The following is a description of a gene set: Human Gene Set: PULVER_FOREY_CELLCYCLE_PEAKING_G2 Transcription regulation during the cell cycle is crucial for ensuring genes are expressed at the right time and in the correct amounts, coordinating key processes like DNA replication, mitosis, and cell division. In our study, Genes whose expression fluctuates during the cell cycle (pVal < 0.05) and peaks in G2 (G2) in K562 studied in species Homo sapiens, and this is the list of marker genes: TENT4A, LYPLA2, SPAG7, KIF23, KAZN, SMARCA4, OR2W3, GTF3C2, UCP2, DNPEP, TBCD, LMAN2L, CCT3, VARS2, RBM19, SLC10A4, TRAP1, PSKH1, TMEM185B, MTHFR, MAP1B, TMEM87A, KIF20B, TMEM250, MAP2K7, RAB1B, ENPP3, RRP1, CAMTA2, JAK2, AP2B1, APEX1, CD151 (CD151 molecule (Raph blood group)), BOD1, RBSN, RFT1, PSMC3, DDX39A, ARHGAP35, YIF1A, DNAJA3, CCNG2, MSL1, NELFE, DPF2, EFTUD2, PPIL2, SMARCB1, MRPL12, POLH, PLCD1, MEX3C, FBXW5, NFIX, CLPP, ASCC2, CUX1, CAVIN2, DCPS, DCAF15, SASH1, MED16, LMLN, MRPL28 (mitochondrial ribosomal protein L28), IRF2BP2 (NCBI Gene Id 359948), ARHGAP4, RCCD1, KMT5A, LSR, NPRL3, PLCL1, CENPC, CDR2, HECTD4, MBD6, ASCC1, NDC80, CDCA2, ANLN, ARAF, WNK4, TNFRSF8, BRD4, SGSM3, SPAG5, CCDC77, CYTH2, VPS37C, CENPT, STK36 (serine/threonine kinase 36), DIS3L2, UBL4A, SNX17, MUC1, NISCH, AFG2A, TUBGCP2, COL25A1, EPN1, BAMBI, MMP17, FADD, GAB2 (NCBI Gene Id 9846), PTPN7, SETD1B, DCTN2, MLST8, CHMP7, ABCC1, VPS4A, R3HDM2, STK25, ARID1B, DTYMK, CERS2, MYO3B, BAG6, USP54, TSEN2, SNAPC3, PARPBP, ACTN1, VAC14, SLC40A1, EVL, UBXN10, GATAD2B, PGP, ID1, PSAT1, AAAS, MON1A, GATA2 (NCBI Gene Id 84724), TAF8, INTS1, ARHGAP19, NMT1, HYAL2, CIZ1, HIPK2, F2RL3, SPOUT1, CEP250, DMAP1, MECP2, DUS1L, AKT1, PNRC2, BICRA, SNRPA, DCAF4, MMAB, TTK, ZNF414, FARSA, CDC25C, PPM1E, CTDNEP1, WIZ, INPP1, COQ5, RNF214, COPS7B, WDR62, MTHFD1L, CABIN1, TXNDC15, TPX2, RAB3GAP1 (NCBI Gene Id 338380), STRIP2, PFKP, PITX1, HDDC3, RPTOR, IGF2BP2, FPR3, NQO2, NUTM2A (NUT family member 2A), VPS51, CENPI, HK1, GP6, MKI67, CMTR1, EPHB4, PLXNA1, TTC9C, LIG3, SEMA4B, C10orf95, LSM2, MTRFR, ACTN4, HCG27, PFKL, POC5, SLC6A9, USP5, AURKB, SLC35A4, ATL2, FADS2, MPDU1, IL16, ARHGAP11A, CLASP2, WDR18, PPP1R35, IGFBP4, ZNF518B, NUSAP1, EARS2, SUGP2, STC2, ZNF628, BORA, SGF29, RHEB, MED22, CCDC97 (NCBI Gene Id 90324, coiled-coil domain containing 97), SAMD4B, NOC4L, SCAMP4, TARS2, KNL1, SPEN, NUDT6, STARD8, MADD, SAP30, ZNRF3, ARHGDIA (Rho GDP dissociation inhibitor alpha), CMSS1, BICD1, BEX1, DSTYK, HARS1, ABCF1, FAM193A, SEC22C, TAF5, PCK2, ZC2HC1C, SLC7A5, NEU3, MICAL3, ATF4, ZNF574, C3AR1, LMNB1 (NCBI Gene Id 445266), SLC27A2, CBS, TAF4, KLF6, GNB2, DDX41, CXXC5, ARHGAP33, DBF4, PGPEP1, LONP1, ANAPC7, MPI, MSL2, EIF3B, ALKBH5, ENO1, NCOR1, ETV5, ASXL1, SMURF1, TBC1D31, VPS25, MRPS2, KIF18A (kinesin family member 18A), CREBBP, JMJD8, STK11, TRUB2, MED29, OSBP, ANKRD54, HTT, CDKN1B, NUDCD3, TSKU, MYC, ACTMAP, KCNK5, CEP89, KIFC3, USP20, ZC3HC1 (NCBI Gene Id 51530), SARS2, MIS18BP1, DEPDC1B, AIP, NCAPH, HNRNPUL1, DCHS1, PPP4R1, DUS2, OIP5, POC1A, TNKS, KCNAB1, COG4, KDM5C, CEP85, SLC4A2, STAT5B, RRP12, IFRD2, XRRA1, TFAP4, PIN1, DHX8, MRPL16, TAFAZZIN, PRRC2A, GMPR, POLG, NCOA5, MEIOSIN, ARL2, SPRED2, SAPCD1, KIAA0586, SREBF2, SH2B3, PAFAH1B1, C2orf69 (NCBI Gene Id 205327), NAIF1 (NCBI Gene Id 203245), SREBF1, MARK3, NOTUM, CLCN6, DAP3, MINPP1, MYO1D, PMF1, ABCA2, ZNF787, POLD2, PHF20, HJURP, RHEBL1, NCOR2, UBR5, TRAF7 (TNF receptor associated factor 7), KIF22, METTL4, SERTAD3, ZNF697 (NCBI Gene Id 90874), RREB1, MKS1, PAN2, TRMT1, ECSIT, MEPCE, THOC6, EMD, NCSTN, FNBP4, ECT2, INCENP, PEX14, PHACTR4, TYK2 (NCBI Gene Id 7297), KIAA1614, PCSK6, TOR1B, CCNA2, ERI3, YJU2, VPS52, KSR1, EHMT1, CIT, UBQLN4, CDK1, CNKSR3, DDX27, MYADM, EP400, ZBTB42, AUP1, ATF7, BLTP2, IER5, TNFRSF10A, RUFY1, SIK3, CDK16, MTX1, TRAF3, FAM234A, CEP55, COQ7, MYH9, HCFC1R1, RAB11B, FAM72D, PIEZO1, ZC3H4, COASY, DYNC1H1, TALDO1, DMBX1, ZNF609, AIRIM (NCBI Gene Id 54955), NT5C, IDH3G, LMO2, C6orf89, AHCYL1, KIFC1, CRY2, SMG5, TMEM268, VPS72, ZFAND2B, CUEDC2, SGO1, SLMAP, TMEM138, MED24, TRIB3, EIF2B2, SF1, SEPTIN9, KDM3B, XPO5, SLC25A25, SAYSD1, FLOT2, ATP6V1E2, TGIF1, BAP1, CKAP2L, CARS1, SDR39U1, PCYT1A, MGAT2, RPAP1 (RNA polymerase II associated protein 1), CENPW, NCLN (nicalin), PPP1R3C, CKS1B, LIPG, NBAS, HGH1, GABRE, HDLBP, AP1B1, HECTD1, MARS1, RPUSD2, NSFL1C, NIF3L1, SPN, DOT1L, TBL2, ZMAT2, NIBAN1, RHNO1, SFSWAP, TTLL12, PHGDH, ABCB8 (NCBI Gene Id 11194), NQO1 (NAD(P)H quinone dehydrogenase 1), PRSS21, CDC42SE1, CEP131, FOXG1, FBXL15, TBC1D14, MYCL, OGFOD3, FOXA3, PMFBP1, ADD2, RSBN1, SRSF9, CCDC18, SETDB1, DUS3L, ZC3H7A, ITIH5, LARS2 (leucyl-tRNA synthetase 2, mitochondrial), GTPBP2, CDK5RAP1, TM9SF4, ZFAT, NDUFAF3, KIF11, FAM178B, FDPS, SIGLEC8, CBFA2T3, MRPL14, EIF4EBP1, NFKBIA, USP22, UBXN11, FOSL1, TNPO3, DHX16, MFSD11, TNFRSF1A (NCBI Gene Id 8077, TNF receptor superfamily member 1A), TRIM24, DENND1A, DCAF7, GLYR1, SLC29A2, ST3GAL3, GRAP2, G3BP1, PRC1, HERC1, NUF2, ARMC6, WDR74, FOXA2, BTN2A1, HMX3, LARP1, AKT2 (NCBI Gene Id 208), FAM50A, ANK1, SPAG9, AP1M1, RGS14, RAB10, UNKL, VCP, BUB3, SRGN, SLC25A1, MAD2L2, TAB1, NUP98, ZBTB3, MFGE8, TNPO2, MANBAL, ZNF318, RPUSD4, CDKN2C, TACO1, APOLD1 (apolipoprotein L domain containing 1), WDPCP, TRPC4AP, ARIH2, ANKRD27, FDFT1, EIF2B5, EYA3, MLLT1, UNC13B, TTC7B, PDIK1L, HM13, DOCK8, CCM2, PRPF31, UQCRC1, TOP2A, EMC10, ARHGAP6, DNAL4, CALCOCO2, MICU1, BUB1B, ATP6V0A1, GPS1, FAM72A, TUBD1, SAMD1, UTP18, EIF2AK3, FAM89A, KIAA0319L, STK11IP, TXNRD2, ANAPC16 (NCBI Gene Id 119504), IARS1, RECQL5, TTC28, CFLAR, ST3GAL2, TOMM40L, RHOH, VSTM4, YBX3, MINK1, PIM2, IRF2BP1, CDCA3, NLE1, WDR6, GANAB, EIF4G3, HSPA1L, GPR68, KPTN, BLOC1S3, SEPTIN8, B4GALNT1, S1PR3, USP6NL, ZC3H3, WASF2, FCHO1, RCC2, NFE2, UROD, TYMP, ZCCHC14, KIF18B, SMYD5, TIMM44, PUS1, CSTF1, RIPK1, ZCCHC8, TMEM231, SMARCD1, CLPB, ITGA4, ESPL1, PROSER3, CTU2, PSMB5, ANKRD11, GLB1L, LDLR, CDC42EP1, FOXK2, MYLK2, BCL2L1, ZDHHC12, MTG2, HLCS, PPAN, PCED1A, B3GALT6, MECR, KLHL12, HMGB2, SCAMP3, PTPRB, STRIP1, WDR25, PRMT1, ZSCAN22, TUBB4B, SSBP4, KIF2C, IQGAP3, MIDEAS, IQSEC1, USF2, HYLS1, DGKZ, FBXO34, ZDHHC14, NME6 (NCBI Gene Id 10201), FAM83D, WWP2, DUSP16, RELA, PPP1R7, ENOX2, FAAP100, TDP1, RNF220, TRAPPC9, RETREG2, TPCN1, PPP1CA, EEFSEC, ABCF2, HSCB, AFG3L2, HSF1, AKAP6, HES1 (hes family bHLH transcription factor 1), COQ9, MAST4, BORCS6, UBC, ATXN7L2, ESRRA, MAGI1, MXD3, FAM216A, GNB1, SNX12, DYRK3, NCAPG, CDC27, FIZ1, PIM3, ZFP36L2, ATN1, PGD, H2AX, FAM83H, MPRIP, NFATC3, ACIN1, THOP1, GSE1, FAM120A, SPPL3 (NCBI Gene Id 25881), ZFAND4, TCF25, YARS1, DHX37, RNF24, DIAPH1, PAPPA, NUCB1, RACGAP1, RABL6, ARF6, C1orf43, ZNF511, ENSG00000187951, MYEOV, PTK2, CKAP2, STK40, RABGGTA (Rab geranylgeranyltransferase subunit alpha), MED8, VEGFA, UCK2, ZC3H7B, MRPL15, SLX4, PKN3, CAMKK2, CANT1, UBN1, ENDOG, RAI1, HDAC6, CENPF, MORC2, MMS19, SARS1, ATRAID, GGA1, RAB8A, NUMA1, PHF19, CHD6, SNUPN, SMAP2, CSNK1G2, CASC3, ELK1, TOR2A, MAF1, KMT2D, COLGALT2 (NCBI Gene Id 23127), TMEM158, TMEM94, GLUL, SLC43A2, TPST2, TMEM259, TCTN3, PRR14, HMGCR